Given this list of marker genes Ms4a4b, Zeb2, Pabpc4, Pkp4, Slc24a5, Rfesd, Srsf6, Ppwd1, Slc18a3, Lcorl, Adgb, Pdp1, Gpr22 (NCBI Gene Id 73010), Lin7a, Rab2a, Stk16, Zfhx3, Bmx (NCBI Gene Id 22176), Vmn1r71, Emc7 (ER membrane protein complex subunit 7), Arfgef1 (ADP ribosylation factor guanine nucleotide exchange factor 1), Mtmr4, Nipal1 (NCBI Gene Id 70701), Mier3, Tmem167, Bhlhe22, Ereg, Wnk1, Anapc10, Ncbp2, Gm14295, Frmd4b, Wdr44, Ednra, Heph, here is a description of the gene set: Mouse Gene Set: MIR_192_5P Genes predicted to be targets of miRBase v22 microRNA mmu_miR_192_5p in miRDB v6.0 with MirTarget v4 prediction scores > 80 (high confidence targets). studied in species Mus musculus from publication Chen Y, Wang X (PMID 31504780)